Given this list of marker genes ACTL7B, OR13C5, MTND3P4, UPF3AP3, OR13F1, GNG10, SMC2-DT, ALDOB, RALGAPA1P1, TMEFF1, RNU6-329P, ACTL7A, ELP1, C9orf152, LINC03094, NR4A3, RN7SKP87, RAD23B, MRPL50, ZNF483, LINC01505, CCSER2P1, RNF20, NIPSNAP3A, RPL7AP44, TMEM245, SVEP1 (sushi, von Willebrand factor type A, EGF and pentraxin domain containing 1), PLPPR1, CAVIN4, RNU6-1064P, STX17, ENSG00000232939, LINC00587 (NCBI Gene Id 414319), ABITRAM, TRPC6P4, RPS15AP27, TOPORSLP, MIR3927, YBX1P6, ERP44, FKTN-AS1, RNU6-996P, RNU6-492P, MIR32, ENSG00000230782, ENSG00000299203, ARL2BPP7, FSD1L, PPP3R2 (NCBI Gene Id 5535), CYLC2, OR13C3, DNAJC25 (NCBI Gene Id 548645), RPL31P43, ABCA1 (NCBI Gene Id 8371), INVS, DPPA3P10, OR13D1, NIPSNAP3B, SMC2, ENSG00000227531, SHOC1, RN7SL75P, TAL2, MIR8081, RPL36AP6, MSANTD3-TMEFF1 (MSANTD3-TMEFF1 readthrough), GAPDHP26, TMEM38B, TXNDC8, RPL21P87, ENSG00000298775, OR13C2, ACNATP, LINC01509, RNU6-710P, PPIAP88, NAMA, TMEM246-AS1, RPS2P35 (ribosomal protein S2 pseudogene 35), KLF4, RNA5SP293, RNY4P18 (NCBI Gene Id 100379298), EPB41L4B, UGCG (NCBI Gene Id 7357), FKTN, RNU6-1013P, RPL36P14, MSANTD3, MIR7702, CHCHD4P2, LRRC37A5P, ZNF189, SLC25A6P5, TEX10 (NCBI Gene Id 54881), PGAP4, ACTG1P19, MTND2P11, OR13C4, ZNF462, RNA5SP292, RNU6-432P, HMGN2P32, OR13I1P (NCBI Gene Id 79538), TRMT112P4, RNU6-1039P, OR13D2P, TXN, OR13C9, SLC44A1, RNU6-984P, NANOGP5, PALM2AKAP2, DNAJC25-GNG10 (DNAJC25-GNG10 readthrough), LPAR1, PTPN3, RN7SL659P, RN7SKP191, ECPAS, LINC01492, RNA5SP291, GRIN3A, OR13C1P, LINC02977, FYTTD1P1 (forty-two-three domain containing 1 pseudogene 1), MUSK, OR13C8, RPL36AP35, BAAT, CT70, RNA5SP294, OR2K2, DEPDC1P2, FRRS1L, ZYG11AP1, OR13D3P (olfactory receptor family 13 subfamily D member 3 pseudogene), MIR4668, CTNNAL1, PTGR1, RN7SKP77, here is a description of the gene set: studied in species Homo sapiens Human Gene Set: chr9q31